The following is a description of a gene set: species: Homo sapiens part of: FGFR2 mutant receptor activation Reactome Pathway: Activated point mutants of FGFR2 Autosomal dominant mutations in FGFR2 are associated with the development of a range of skeletal disorders including Beare-Stevensen cutis gyrata syndrome, Pfeiffer syndrome, Jackson-Weiss syndrome, Crouzon syndrome and Apert Syndrome (reveiwed in Burke, 1998; Webster and Donoghue 1997; Cunningham, 2007). Mutations that give rise to Crouzon, Jackson-Weiss and Pfeiffer syndromes tend to cluster in the third Ig-like domain of the receptor, either in exon IIIa (shared by the IIIb and the IIIc isoforms) or in the FGFR2c-specific exon IIIc. These mutations frequently involve creation or removal of a cysteine residue, leading to the formation of an unpaired cysteine residue that is thought to promote intramolecular dimerization and thus constitutive, ligand-independent activation. Mutations in FGFR2 that give rise to Apert Syndrome cluster to the highly conserved Pro-Ser dipeptide in the IgII-Ig III linker; mutations in the paralogous residues of FGFR1 and 3 give rise to Pfeiffer and Muenke syndromes, respectively. Development of Beare-Stevensen cutis gyrata is associated with mutations in the transmembrane-proximal region of the receptor, and similar mutations in FGFR3 are linked to the development of thanatophoric dysplasia I. These mutations all affect FGFR2 signaling without altering the intrinsic kinase activity of the receptor.<br><br><br>Activating point mutations have also been identified in FGFR2 in ~15% of endometrial cancers, as well as to a lesser extent in ovarian and gastric cancers. These mutations are found largely in the extracellular region and in the kinase domain of the receptor, and parallel activating mutations seen in autosomal dominant disorders described above.<br><br><br>Activating mutations in FGFR2 are thought to contribute to receptor activation through diverse mechanisms, including constitutive ligand-independent dimerization, expanded range and affinity for ligand and enhanced kinase activity., and this is the list of marker genes: FGF16, FGF3, FGF6, FGF18, FGF22, FGF1, FGF4, FGFR2, FGF8, FGF20, FGF23, FGF10, FGF5, FGF7, FGF17, FGF2, FGF9